Given this list of marker genes KLF5, FOXO1, IDO1, TLR4, AFMID, CAT, IL1R2, IDO2, KYNU, TDO2 (NCBI Gene Id 6999), AADAT, AHR, NOS1, IFNB1, TNF, TP53 (NCBI Gene Id 7157), EIF2AK1, CDKN1A, ACMSD, IFNG, HAAO, EIF2AK4, QPRT (NCBI Gene Id 23475), KMO, here is a description of the gene set: Human Gene Set: WP_KYNURENINE_PATHWAY_AND_LINKS_TO_CELL_SENESCENCE studied in species Homo sapiens Kynurenine pathway and links to cell senescence